The following is a description of a gene set: The chemical reactions and pathways resulting in the formation of pyrimidine nucleoside diphosphate, a compound consisting of a pyrimidine base linked to a ribose or deoxyribose sugar esterified with diphosphate on the sugar. species: Homo sapiens Human Gene Set: GOBP_PYRIMIDINE_NUCLEOSIDE_DIPHOSPHATE_BIOSYNTHETIC_PROCESS, and this is the list of marker genes: CMPK2, CAD, DHODH, AK9, UMPS, CMPK1, DTYMK